The following is a description of a gene set: species: Mus musculus Mouse Gene Set: WP_GPCRS_ORPHAN GPCRs, orphan, and this is the list of marker genes: Gpr107, Tpra1, Gpr180, Gpr137c, Gpr31b, Gpr137b (NCBI Gene Id 97883), Gpr4, Gpr89, Adgrg4, Gpr179, Gpr137, Wls, Adgrf5, Gpr155, Gpr161 (G protein-coupled receptor 161), Gpr108, Vmn2r-ps54, Gpr165, Adgrf2